The following is a description of a gene set: Short mandibular rami Human Gene Set: HP_SHORT_MANDIBULAR_RAMI species: Homo sapiens, and this is the list of marker genes: GNAI3, KCNJ2, EDN1, PLCB4, NFIX, HMX1